Given this list of marker genes B4GALNT2, RNF212, TUBB2B, TSPAN2, LAIR1, WFDC11, ZDHHC12, SP5, RBMS1, CTLA4, LGR5, VPS37D, ADD3, TPD52, MIR125A, PKDCC, NEB, CD79B, CDK20, RCN1, OPRL1, CDKN1A, SUSD1, DDX60, ATP13A3, LY6D, GZMB, IFITM3, CALHM4, PRR5, DTNBP1, DDC, UCK2, RNF130, MYOF, DSP, CNKSR2, IGF2, B3GNT2, COL12A1, CDH23, FHL1, ODAD1, ERG, ECEL1, LY75, NXPH1, GPR153, IFNGR1, RBM24, MCOLN3, ABCA4, HOXB5, KIFC2, TGFBR1, CDH1, UBA1, IGF2-AS, NBEAL2, GBGT1, AVPR1A (NCBI Gene Id 552), OIT3, SOCS2, SPAG16, POU2F3, SCIN, EPCAM, PAPSS2, IL18BP, PCGF5, HDAC4, RIGI, CD164L2, CSRP3, DPT, TMEM17, SOCS3, MMP25, MIR7-2, NEDD4L, LMOD1, LDLRAD1, TUBB2A, DNAI4, DNAJC6, DEGS2, EXOC3L2, TMEM71, SLC66A3, CMTM5, LIMS1, AHR, TCHP, PREX1, KCND2, S100A11, HIVEP3, CALCRL, LDLR, ATRNL1, AMER2, AMH, GGH, COL9A1, MSMB, GBP4 (NCBI Gene Id 115361), CADPS2, PLD4, ARMCX3 (NCBI Gene Id 51566), ITGB4, SERF1A, TOX3, NUDT4, KRTAP4-6, GCK, STXBP5, HTR3B, TAFA3, CCDC85A, PDE5A, PLK3, SAMD9L, ESPN, PLXNA4, GBP6, PLAAT3, ARNT2 (aryl hydrocarbon receptor nuclear translocator 2), DLGAP1, ACOT7, ZFR2, SHROOM1, NEBL, HBQ1, LGALS1 (NCBI Gene Id 3956), TASP1, PPT1, REEP5, FBXW7, HOXA2, PSMB9, SGTA, HYCC1, TCF7L2, FAM43A, GATA2, SLC25A12, DISP3, MCOLN2, NRG2, PTPRF, APLP2, SEC31B, ANXA2, ITGA4, EPSTI1, PAQR9, NCOA7 (nuclear receptor coactivator 7), CYP51A1, H19, MYL10, PDIA2, CALM1, MIR375, ALPK1, ISLR, here is a description of the gene set: Human cytomegalovirus induces a pro-inflammatory monocyte following infection and we have evidence that NF-κB and phosphatidylinositol 3-kinase are key mediators in this early activation. To begin to address how these signalling pathways are responsible for the rapid activation of infected monocytes, we examined the role these pathways played in the transcriptome of infected monocytes. Global transcriptional profiling using cDNA microarrays revealed a significant number of genes, including inflammatory genes, were regulated in a NF-κB- and/or PI(3)K-dependent manner, identifying these pathways as key cellular control points in the conversion of monocytes to an activated pro-inflammatory state following HCMV infection. studied in species Homo sapiens Genes up-regulated in monocytes after HCMV infection: untreated versus BAY 11-7082. Human Gene Set: GSE9601_UNTREATED_VS_NFKB_INHIBITOR_TREATED_HCMV_INF_MONOCYTE_UP from publication Chan G, Bivins-Smith ER, Smith MS, Yurochko AD (PMID 18003728)